The following is a description of a gene set: Neighborhood of TAL1 T-cell acute lymphocytic leukemia 1 in the GNF2 expression compendium Neighborhood of TAL1 Human Gene Set: GNF2_TAL1 studied in species Homo sapiens, and this is the list of marker genes: TRAK2, TMCC2, GYPC, CAT, GYPE, TAL1, MINPP1 (NCBI Gene Id 9562), AHSP, CA2, SLC22A4, NUDT4, ALAS2, KLF1, SPTB, TSPO2 (translocator protein 2), FBXO7, BNIP3L, CROCCP2, RANBP10, HBD, UROD, ERMAP, EIF2AK1, H1-0, CA1, ALAD (NCBI Gene Id 210), KEL, ICAM4, FECH, SNCA, HEBP1 (NCBI Gene Id 50865), EIF1AY, SELENBP1, GLRX5, RAD23A, SPTA1, PPOX, RHD, HDGF, BMP2K, MPP1 (NCBI Gene Id 4354), TFRC (transferrin receptor), PRDX2, BLVRB, HMBS, GCLM, MARCHF8, RHCE, SLC12A3, UBAC1, NARF, HBQ1, ADD2, GATA1, XPO7, OSBP2, DCAF11, GYPB, TRIM10, H4C3, MAP2K3, TSPAN5, CLIC2, CDC27, NFE2, GYPA (NCBI Gene Id 2993), RHAG, SLC4A1 (solute carrier family 4 member 1 (Diego blood group)), TFDP1, EPB42, CTSE, XK, ANK1